The following is a description of a gene set: Human Gene Set: GOBP_PYRIMIDINE_RIBONUCLEOSIDE_MONOPHOSPHATE_METABOLIC_PROCESS species: Homo sapiens The chemical reactions and pathways involving pyrimidine ribonucleoside monophosphate, a compound consisting of a pyrimidine base linked to a ribose sugar esterified with phosphate on the sugar., and this is the list of marker genes: UCK2, UPP1, UPB1, UCKL1, DPYD, NT5C (NCBI Gene Id 7370), UPP2, CMPK1, UPRT, DPYS, UCK1, UMPS, DCK, CDA, DHODH, CAD